The following is a description of a gene set: Human Gene Set: GOCC_COLLAGEN_TYPE_IX_TRIMER studied in species Homo sapiens A collagen heterotrimer containing type IX alpha chains in alpha1(IX)alpha2(IX)alpha3(IX) trimers; type IX collagen triple helices associate to form a structure that links glycosaminoglycans to type II collagen fibrils., and this is the list of marker genes: COL16A1, COL9A3, COL13A1, COL9A1, COL9A2